Given this list of marker genes ABCB7, EYA3, OSBPL11, CUL5, NOL4L, MMP13, BTBD3, RFX7, KLF6, QKI, CBLB, CADM1, FOXF1 (NCBI Gene Id 2294), STOX2, ADAM10, MTCL1, CDC14A, CLCN6, ADAM22, SLC16A6, SNX27 (NCBI Gene Id 81609), ATXN7L1, INHBB, ING2, SECISBP2L, TGFB2, PRKCZ, YWHAB, ELAVL4, NAT14, NRP1, NOL4, LBR, ADCY2, LIPA, ZFYVE26, MLLT6, RGMA, JARID2, PRKAA1 (NCBI Gene Id 5562), ITSN2, CCDC6, CELSR1, NRARP, AGO1, PITPNM2, ADAM17, ARL6IP1, FAM168B, FXR1, KIF14, TBL1XR1, RICTOR, UCP3, DNMT1, CTSA, SIRT7, DYRK2, LYSMD2, LEPROTL1, SOS2, TOMM70, MAP3K4, WDR20, ARFIP1, ITGA5, TMEM170A, TRIM59, NPEPL1 (NCBI Gene Id 79716), KIAA1217, BTBD10, RAB34, GPATCH8, AGO4, DOCK6, EOGT, PRKAG2, SNN, CANX, KRT76, ADAM23, NCKIPSD, ALCAM, ARRDC3, UHMK1, ESRRG, HOMER1, WDR47, CBLL1, SSR1, ZCCHC2, CDKN1B, BICC1, KIAA0232, PRNP, MRAS, EPS15, CHD7, CDS1, MACROH2A1, SNAP91, MIER1, CNTNAP3B, CDH20, CYTH3, NPTN, SLC2A1, ACVR1, FAM43A (NCBI Gene Id 131583), TNRC6A (trinucleotide repeat containing adaptor 6A), PIGA, EFNB2, SBF2, CYB5R4, GTF2H1, E2F7, SIK1, TMEM9B, ATP8A1, NFAT5, KMT2A, IGFBP5, ITGB8, C1GALT1, NHS, SMS, CS, GADD45A, UBE2D3, ARF4, SESN2, SGCB (sarcoglycan beta), ADAMTS19, EPAS1, GMFB, ADAMTS15, TGFA (transforming growth factor alpha), PIK3C2A, GPRC5A, IL15, NOG, DICER1, TANC1, FAM234A, ANGEL2, AP4E1, PEAK1, ZNF821, NEURL4, SZRD1, KCTD16, B4GALT5, UBE4B, AHDC1, SESN3, ITGA9, ELAVL2, RNF38, FMR1, MMP10, CSF1, CLTA, PLAA, EPM2A, DENND4C, USP48, PTGES3, MAFB, LRP2, BMP3, MITF, ZBTB18, MAP3K9, PHF20 (PHD finger protein 20), YTHDC2, PNPLA6, TXNIP, ATP4B, USP32, CABP7, TMED7, ATP11A, TMEM266, GPR137C, SLC26A4, LRRC41, TFRC, HECW2, A4GNT, MMP15, ENSG00000275993, XPO4, BAZ2B, COL4A1, USP31, ZDHHC17, ADGRF5, TGIF2, TRAK2, ANXA4, PDE1C, NR2C2AP, ABCA1, TMEM54, BTAF1 (NCBI Gene Id 9044), LMTK2, ZNF804A, GPM6A, SLC25A44, DDX6, MEOX2, MACIR, HOXC8, ADGRB3, SPTY2D1, CEP55, AGFG1, TGOLN2, STARD13, MLLT10, RC3H1, NME7, CDKL5, MMD (NCBI Gene Id 23531), ATP6AP2, SESTD1, MAFG, ARHGEF12, PPP1R10, USP33, ZDHHC23, WNT1 (NCBI Gene Id 7471), MRGPRX3, MTMR9, MAP2K1, ROBO1, DCP2, PIGS, TENT2, PPP1R9B, SLC24A3, CCT6A, DLG2, RALBP1, KAT7, CIITA, WDFY4, SIX4, SYNJ1, PRICKLE2, TEK, ERRFI1, RAB14, FBN1, DUSP1, MNT, GAP43, MOSPD1, RUNX2, RMND5A, CD72, B4GALT6, VMP1, CNTN4, PHACTR2, PGRMC2, NT5C3A, ZDHHC7, CDK19, GRID2, TNRC6C (NCBI Gene Id 57690), KLF4, ATXN1, CDK5R1, POU3F2, OBI1, CHUK, ATG14, SCN9A, SKIDA1, VCF1, ARHGAP21, SRSF11 (NCBI Gene Id 9295), CASZ1, GPCPD1, UBAP2L, HBS1L, WNT10B, KLF5, RPS6KA5, MPL, ATP2B4, OTUD4, MED12L, TMEM63B, ITPK1, EPN2, S1PR1, GLRX5, TBC1D8, CCDC141, LTBP1, CCKBR, RTN4, ERBB3, DMXL1, AKAP1, CAND1 (cullin associated and neddylation dissociated 1), ESR1, CERS6, KDM7A, F3, BCL2L11, INO80, ARL8B, VPS37A, ARK2N, ABCD3, ROBO2, MTMR10, ROCK1, CAMSAP2, JMY, CFL2, BACH2, PHF3, NPTX1, FEZ2, RANGAP1, MTMR14, FAM161A, LDLR, RBM24, MXD1, VSIG1, PPP6R1, RASSF8, MDFIC, NCOA1, here is a description of the gene set: Genes predicted to be targets of miRBase v22 microRNA hsa-miR-152-3p in miRDB v6.0 with MirTarget v4 prediction scores > 80 (high confidence targets). from publication Chen Y, Wang X (PMID 31504780) studied in species Homo sapiens Human Gene Set: MIR152_3P